The following is a description of a gene set: Human Gene Set: GOBP_WNT_SIGNALING_PATHWAY_PLANAR_CELL_POLARITY_PATHWAY studied in species Homo sapiens A type of non-canonical Wnt signaling pathway in which Wnt binding to its receptor on the surface of a target cell results in the activation small G proteins such as Rho, Rac, and Cdc42 which, in turn activate effectors, including C-Jun N-terminal kinase (JNK) and Rho kinase (Rok). The signaling ends with change in the transcription of target genes and/or reorganisation of the cytoskeleton., and this is the list of marker genes: FZD3, SFRP1, DKK1, NKD1, WNT11, MLLT3, DVL3, DAAM1, SMURF1, MED12, FZD6, CDC42, FZD7 (frizzled class receptor 7), CELSR1, ARHGEF19, WNT9B, MKS1, DAB2, GPC3, SPEF1, ABL1, WNT7B, CCDC88C, WNT7A, PRICKLE1, RSPO3, CELSR2, PRICKLE2, ZNRF3, MAGI2, TIAM1, DVL2, VANGL2, CELSR3, DACT1, ANKRD6, WNT5A, CTHRC1, RHOA, PLEKHA4, FZD2, NPHP3, SMURF2, DVL1, RYK, VANGL1 (VANGL planar cell polarity protein 1), RAC1